Given this list of marker genes Mdga2, Magi2, Pcdh8, Taok2, Mdga1, Lrfn3, Mapk14, here is a description of the gene set: Any process that modulates the frequency, rate or extent of adhesion between pre- and post-synaptic membranes. Mouse Gene Set: GOBP_REGULATION_OF_SYNAPTIC_MEMBRANE_ADHESION studied in species Mus musculus